Given this list of marker genes NOP56, ATP13A2, KCNC3, SPG7, ACBD6, CCDC88C, EIF2AK2, AGTPBP1 (ATP/GTP binding carboxypeptidase 1), PIGT, AASS, MAPT, PLP1, NPC1, NEK9 (NIMA related kinase 9), TWNK, ALDH4A1, POLR3A, MUSK, NPC2, FTL, POLR3B, NKX6-2, PLA2G6, DCTN1, ATXN1, SQSTM1, ACOX2, DLAT, MTFMT, VPS13A, NAXE, POLG, here is a description of the gene set: species: Homo sapiens Human Gene Set: HP_VERTICAL_SUPRANUCLEAR_GAZE_PALSY A supranuclear gaze palsy is an inability to look in a vertical direction as a result of cerebral impairment. There is a loss of the voluntary aspect of eye movements, but, as the brainstem is still intact, all the reflex conjugate eye movements are normal. Vertical supranuclear gaze palsy